The following is a description of a gene set: A protein complex which is capable of acetyltransferase activity. studied in species Homo sapiens Human Gene Set: GOCC_ACETYLTRANSFERASE_COMPLEX, and this is the list of marker genes: SUPT3H, TRRAP, NAA15, SUPT20H, BRPF3, MORF4L1, SF3B3, RUVBL2, ATF2, TAF12, NAA30, TAF4, TADA3, BRD8, KAT5, NAA38, HCFC1, TADA2A, NAA16, KAT8, NAA50, TADA1, TAF5L, SUPT20HL2, MEAF6, KAT6B, EP400, PAAF1, KAT14, POTEF, POLE4, MSL2, KAT6A, BRPF1, MORF4L2, MCRS1, POTEKP, TAF5, OGT, DLD, POLE3, PHF20, EPC2, ATXN7L3, KANSL3, ACTBL2, NAA11, USP22, YEATS4, PHF20L1, DR1, NAA25, KAT7, ACTB, JADE2, YEATS2, ACTL8, JADE3, TAF2, MAP3K7, EPC1, TADA2B, KAT2A, NAA20, ATXN7, SUPT20HL1, KANSL1L (KAT8 regulatory NSL complex subunit 1 like), ING3, RUVBL1, MRGBP, POTEI, VPS72, POTEJ, POTEE, ZZZ3, TAF6L (NCBI Gene Id 55310), BRD1, MBTD1, TAF9, MSL3B, TAF6 (TATA-box binding protein associated factor 6), CREBBP, TAF10, ACTG1, NAA35, SGF29, MSL1, MSL3, DMAP1, MBIP, TAF7, JADE1, EP300, ACTL6A, KANSL1, KANSL2, ACTL6B, WDR5, ING4, NAA10, ING5, SF3B5, ENY2, TAF9B, SUPT7L, KAT2B